Given this list of marker genes Atl3, Lnpk, Atl2 (NCBI Gene Id 70260), Rtn4, Atl1, here is a description of the gene set: Mouse Gene Set: GOCC_ENDOPLASMIC_RETICULUM_TUBULAR_NETWORK_MEMBRANE studied in species Mus musculus The membrane of the endoplasmic reticulum tubular network.